Given this list of marker genes CHST6 (carbohydrate sulfotransferase 6), TBC1D2B, GNPTAB, ROBO3, GATAD2B, here is a description of the gene set: Human Gene Set: HP_HYPEROPIC_ASTIGMATISM A form of astigmatism in which one meridian is hyperopic while the one at a right angle to it has no refractive error. studied in species Homo sapiens Hyperopic astigmatism